Given this list of marker genes MAFB, COL25A1, TUBA1A, CHN1, TUBB2B, TUBB3, KIF21A, SALL4, PHOX2A, here is a description of the gene set: Reduced ability to move the eye in the direction of the nose. Human Gene Set: HP_IMPAIRED_OCULAR_ADDUCTION Impaired ocular adduction studied in species Homo sapiens